The following is a description of a gene set: species: Homo sapiens A congenital anomaly of the urinary tract, in which the kidney is duplicated and is drained via two separate renal pelves and ureters. Renal duplication Human Gene Set: HP_RENAL_DUPLICATION, and this is the list of marker genes: GPC3, TRIP13, ITGA6, STX1A, GP1BB, VPS37D, ZEB2, LIMK1, REST, TMEM270, DVL1, WT1, GPC4, SLC6A17 (solute carrier family 6 member 17), DNAJC30, BRCA2 (BRCA2 DNA repair associated), BUD23, BAZ1B, TBL2, H19, KCTD1, FOXC2, ELN, GP9, B3GLCT, FANCD2, PLEC, GP1BA, GTF2IRD2, KDM6A (lysine demethylase 6A), POU6F2, ITGB4, TRIM28, KMT2D, FKBP6, GTF2I, GTF2IRD1, RPS26, SPINT2, DIS3L2, EIF4H, ROR2, COL18A1, WNT5A, CLIP2, METTL27 (NCBI Gene Id 155368), NCF1, KANSL1, RFC2